Given this list of marker genes IL11 (NCBI Gene Id 3589), AGTR1, HIF1A, RACK1, ACTA2, PTPN11, TGFBR2, TGFBR1, COL1A2, SMAD3, AGT, RAF1, SMAD4, NOX4, IL6ST, ACE2, COL1A1, F12, JUND, CCN2, SP1, MAPK1, PDGFD, RRAS, IL11RA, TGFB1, MAP2K6, MAS1, here is a description of the gene set: studied in species Homo sapiens Angiotensin II receptor type 1 pathway Human Gene Set: WP_ANGIOTENSIN_II_RECEPTOR_TYPE_1_PATHWAY